Given this list of marker genes CFAP53, SPAG17, STK33 (NCBI Gene Id 65975), HOOK1, MEIG1, PFN4, AXDND1 (axonemal dynein light chain domain containing 1), IFT56, CCDC146, CEP131 (NCBI Gene Id 22994), here is a description of the gene set: species: Homo sapiens The aggregation, arrangement and bonding together of a set of components to form a manchette. Human Gene Set: GOBP_MANCHETTE_ASSEMBLY